The following is a description of a gene set: from publication Yosef N, Shalek AK, Gaublomme JT, Jin H, Lee Y, Awasthi A, Wu C, Karwacz K, Xiao S, Jorgolli M, Gennert D, Satija R, Shakya A, Lu DY, Trombetta JJ, Pillai MR, Ratcliffe PJ, Coleman ML, Bix M, Tantin D, Park H, Kuchroo VK, Regev A (PMID 23467089) Human Gene Set: GSE43955_10H_VS_30H_ACT_CD4_TCELL_DN Genes down-regulated in CD4 T helper cells Th0: 10h versus 30h. Despite their enormous importance, the molecular circuits that control the differentiation of Th17 cells remain largely unknown. Recent studies have reconstructed regulatory networks in mammalian cells, but have focused on short-term responses and relied on perturbation approaches that cannot be applied to primary T cells. Here, we develop a systematic strategy – combining transcriptional profiling at high temporal resolution, novel computational algorithms, and innovative nanowire-based tools for performing gene perturbations in primary T cells – to derive and experimentally validate a temporal model of the dynamic regulatory network that controls Th17 differentiation. The network is arranged into two self-reinforcing and mutually antagonistic modules that either suppress or promote Th17 differentiation. The two modules contain 12 novel regulators with no previous implication in Th17 differentiation, which may be essential to maintain the appropriate balance of Th17 and other CD4+ T cell subsets. Overall, our study identifies and validates 39 regulatory factors that are embedded within a comprehensive temporal network and identifies novel drug targets and organizational principles for the differentiation of Th17 cells. species: Homo sapiens, and this is the list of marker genes: SET, SELENOT, FDPS, ZSCAN26, BID, SRRT, TRAFD1, RAN, ELOVL6, CSTPP1, STK11IP, MMP12, HIC1, MYORG, POU2F1, RRAGC, SCG2, SERPINA5, PCCB, CCNI, EPHA8, CASP12, SCAMP1, BUD31, PRKCQ, GSTM5, PTGER2, PDPK1, C9, UGCG, CLOCK, F8, PPP2CB, CCR1, SOS2, WBP2, DGCR2, KSR1, RPS16, MSMO1, RPS10, SOCS3, E4F1, LAMA3, WNT7B, SPIC, CITED1, ATP1B2, CGGBP1, HADH, ENY2, PIAS2, JMJD8, RYR2, C1GALT1C1, CASP4, DIO2, SEMA3C, ARF1, RPL18, STRN4, STT3A, SETDB1, KPNB1, MPG, SHC1, FBXO38, SLC12A1, PRPF8, FOXRED1, VKORC1, CYB5B, PLA2G6, PLA2G7, LRRC59, ITLN1, MSMB, CDC5L, SDC2, CD83, CYP2J2, PKIA, RAMP1, BCL7C, ST3GAL5, MKNK2, HMBOX1, CLCN7, GLRX3, ATG12, STRN3, UPK2, RCL1, HIP1R, PSIP1, ABCF3, RBM14, ARHGDIB, GRIA3, HEBP1, PRKG2, ZC3H12C, RAB21, RNF166, ADH7, AKT2, NRBP1, NANOG, CENPK, TGFBI, AHNAK, MCOLN2, ACYP2, BASP1, FAM241A, SAR1A, CNTNAP1, UQCC3, SGPL1, CCDC93, CACUL1, TGFA, GLI1, IKBKE, MYH4, PLK2, ANKIB1, PDIA5, GAD2, YY1, CRY1, CNP, SYT9, ORC5, HOXB6, WNT1, ALKBH5, MAGEH1, YBX2, IL7, C2, DIO1, SORBS1, PDCD7, ZNRF4, ITGAE, NAV1, PGK2, PRAP1, C2CD2, PLA2G2C, IGFBP4, STX5, AKT1, P4HA1, LDLR, LCN2, KRT16, NR2C2, CFB, GJA8, MTMR14, BPHL, DIP2B, TAT, SERPINB2, TNPO1, FGFBP1, RNASE1, H1-8 (H1.8 linker histone), OGFR, NUB1, CR1L, BHLHE40, BPNT1, MRPS18B, TIAL1, NCF4, TNNI1, ALCAM, STXBP2, VPS26B, IMP3, NPNT, SAAL1, ZFAND2A, IL13RA1, NEUROG1, NAPSA, TERT, NTF3, RPS6KB1, ORMDL1, GDE1, ELK1, TRAF2 (NCBI Gene Id 7186), HP, AMACR, TNPO3, INMT